The following is a description of a gene set: studied in species Homo sapiens Human Gene Set: GOBP_STRIATED_MUSCLE_CELL_DIFFERENTIATION The process in which a relatively unspecialized cell acquires specialized features of a striated muscle cell; striated muscle fibers are divided by transverse bands into striations, and cardiac and voluntary muscle are types of striated muscle., and this is the list of marker genes: AKAP13, HDAC4, PI16, KDM6B, MIR19A, BDNF, KCNH1, MIR24-1, GPX1, CD81, ADGRB1, EFNB2, CYP26B1, NFATC2, PLD3, TMEM119, MYBPC1, CCNB1, EZH2, MIR200B, CASP7, CACNA1S, PITX2, DOCK2, LARGE1, TBX5 (NCBI Gene Id 6910), MYORG (NCBI Gene Id 57462), MIR199B, PAK1, FHL2, FBXO22, TNFSF14, IFT20, ACTN2, SYNPO2L, SMYD1, PRKD1, SOX6, CSRP2, PLEC, TBX1, BNIP2, BARX2, MYEF2, CDH2, MYH9, CBY1, CAV2, KLF5 (KLF transcription factor 5), PDLIM5, RARA, SIRT6, IGF2, FOXP1, ASB2, ADAMTS5, SPAG9, CFL2, KCNJ8, MAMSTR, MIR23A, PIEZO1, NRG1, RIPOR2, NLN, PDGFRA, BVES, AVPR1A (arginine vasopressin receptor 1A), NRAP, RBM24, PARP2, MYO18B, POPDC2, LMOD3, BIN3, CNTNAP1, NPPA, TMOD4, MYOG, FKTN, MTOR, MYL2, ADAM12, POPDC3, NOS1, PRKAR1A, RARB, SELENON, MIR1-1, G6PD, PGM5, MIR195, SORBS2, DMPK (NCBI Gene Id 60405), DOCK5, PLPP7, KAT2A, GDF15, PROX1, IGF1, GSK3A, AKAP6, TOMM70, TRIM72, EDN1, NOTCH1, SDC1, MIR206, SGCB, SIX1, NKX2-6, LDB3, OBSCN, CASQ1, BMPR1A, WNT10B, ACTA1, MIR499A (microRNA 499a), FZD7, TNNT2, TGFB1 (transforming growth factor beta 1), PTGFRN, MYLK3, VEGFA, MIR133B, KLHL40, PPARA, MYMX, MESP1, MYOD1, HDAC5, ERVW-1, ADAMTS15, FKRP, CFLAR, MYMK, CAV3, TTN, ITGB1, TRIM32, RGS2, CSRP1, EHD2, MTLN, YBX1, FLII, DYRK1B, SIX4, FLNC, MAML1, BMP2, MIR222, KRAS, ACTN3, ACTC1 (NCBI Gene Id 70), RB1, TMOD2, MYF6, MYH11, OBSL1, CTDP1, ADPRHL1, LMNA (NCBI Gene Id 7816), SMAD4, MAPK14, TSC1, CD53, ISL1, CDON, GREB1L, TANC1, ACTG1, MEIS1, MYBPC2, ADGRB3, MYOM1 (myomesin 1), PPP3CA, HOMER1, RPL3L, ZMPSTE24, CTCF, AKT1, SKI, ADRA1A, LMOD1, MIR199A1, BMP10, WNT3A, CHUK, MYOM2, EHD1, PRICKLE1, CEACAM5, PPIF, BCL2, NKX2-5, COL14A1, RYR1, MYH6, MYOM3, IGFBP5, CAPN2, MIR590, SHOX2, CAPN3, CACNA1H, NEO1, BCL9, MEF2A, TPM1, MYL9, MIR19B1, MEF2C, WNT1, RCAN1, FLOT1, TMEM182, HDAC3, ACADM, MSX1, CXADR (CXADR Ig-like cell adhesion molecule), TMOD1, BHLHA15, BMP4, HNRNPU, ERVFRD-1, SLC8A1 (NCBI Gene Id 6546), MYBPC3, TCAP, ATP11A, BHLHE41, SMO, RBM38, SIK1, PDGFRB, SLC9A1, MYH10, PPP3CB, DOCK1 (dedicator of cytokinesis 1), MYBPH, LMOD2, SMYD3, NEB, GATA4, NAGLU, DNER, RGS4, TMOD3, ALPK3, WDR1 (WD repeat domain 1), TBX3, MYOZ1, SGCD, ARRB2, SORT1, FHOD3, CDK1, CXCL9, NOX4, FRS2, P2RX2, DKK1, CACYBP, MMP14, ANKRD23, LRRC10, TNNT1 (NCBI Gene Id 7138), TBX18, HDAC1, MYOCD, CXCL10, NEBL, MYH3, MYF5, HEY2, COL6A1, KRT19, MIR208A, WT1, KEL, XBP1, HOPX, TNNT3, SPG11, CD9, CSRP3, ALPK2, MYOZ2, CASP3, ATG5, ANKRD1, DCAF8, B4GALNT2, SRF, IRX3, GREM1, ACVR1, HDAC9, NPHS1, PLEKHO1, MYC, CCL8, IL4R, C10orf71, PRKG1, ANHX, RXRB, KLHL41, YY1, SHH, SCGB3A1, DLL1, MYPN, MIR204, CALR, GATA6, CCN3, XK, STAC3, NACA, MIR133A1